The following is a description of a gene set: Human Gene Set: PID_EPHA2_FWD_PATHWAY from publication Schaefer CF, Anthony K, Krupa S, Buchoff J, Day M, Hannay T, Buetow KH (PMID 18832364) studied in species Homo sapiens EPHA2 forward signaling, and this is the list of marker genes: SRC, PIK3CA, TIAM1, VAV3, PTK2, BCAR1, INPPL1, PIK3R1, PAK1, ARHGAP35, CBL, ACP1, EPHA2, RAC1, VAV2, GRB2, SHC1, EFNA1, RHOA